Given this list of marker genes RAP1B, LNPEP, DDRGK1, CEP95, EBP, HASPIN, DOCK2, TRAM1, CIMIP4, SUOX, TTLL8, MKRN2, RASL11A, GAS7, MON1B, C2orf76, PPP2R5A, GAN, BNIP2, INAFM1, PEA15, ALKBH7, FAM241A, CMTM6, STMN1, SEPTIN2, RAD23A, IGBP1, TBCB, PCDHB16, GP1BA, CGAS, AKTIP, RIDA, KLHL42, FOXO3, RBM42, FGF11, AHDC1, LXN, CDC42SE1, CYTH2, CAMK2G, PPP3CC (NCBI Gene Id 5533), ARHGAP9, MLLT6, TRMT10B, MRPL33, ZNF394, HMGCR (3-hydroxy-3-methylglutaryl-CoA reductase), EDC4, LGALS1 (galectin 1), TACC3, TNS2, FZD5, RFTN1, WDR53, HEXB, CEP55, TRIM24, DNMT1, TTC39C, DPCD, CRIPT, PSKH1, ERCC6L, RAP2B, CAPN2, IDH3A, CAMK1D, CYB561A3, RASSF7, BTD, GATA3 (NCBI Gene Id 84828), NFATC3, TECPR1, ATAD1, CALB1, CIMIP5, SUPT4H1, BTG2, FKBP4, PPM1H, SNAI3, STARD7, LPIN1, THUMPD1, PIMREG, SGCB, ITGB7, SYNJ1, EMP3, ANXA4, RNF44, G2E3, ZFAND4, DNAJB1, CDKN2AIP, COMMD7, ACOT8, NCALD, CD96, PKMYT1, AUNIP, STK10, ACOT9, PPM1G, GP5, DNAJB4, ATP10A, SLC20A1 (solute carrier family 20 member 1), GPR87, C14orf93, SPRY2, MARK2, PAG1, GSS, ARL4A, PEDS1, GZMM, PEX5, CKLF, SEPHS2, HCLS1, ZNF335, LRRC8C, VCL, CD164L2, CUTA, REXO5, GNPTG, NIBAN1, SYNGR3, GBP2, OAS2, TREX1, KLC4, LAIR1, ABRACL, FAM204A, LGALS8, CASP7, ITPA, ETS1, HNF4G, GLIPR2, HSPG2, ADGRE5, CYP2D6, ARHGAP19, IKZF1, FCGR2B, TKTL2, NDC80, KIF23, RCN1, CLIC4, ULBP1, GSR, MEGF9, AIMP1, LRRC57 (leucine rich repeat containing 57), DIAPH3, GPSM2, NPC2, KCNAB2, PNLIPRP2, PLEKHF1, ARHGEF2, MYO1F, CYP2S1, AP1G2, ZNF414, USO1, NCCRP1, CERS5, TRAFD1, FAM177A1, GNA11, TUBGCP3, ATOX1, PXYLP1, SGK3, ATL2, PTBP3, MED27, MANF (mesencephalic astrocyte derived neurotrophic factor), ATG7, DHRS7, P2RY13, CDKN3, OSBPL3, MLYCD, STXBP5, EHD4, ANAPC5, KDM4A, APRT, DKK4, PDCD6IP, here is a description of the gene set: from publication Kress E, Hedges JF, Jutila MA (PMID 16423401) Human Gene Set: GSE3720_VD1_VS_VD2_GAMMADELTA_TCELL_WITH_LPS_STIM_DN The two major human gd T cell subsets, Vd1 and Vd2, display differences in tissue tropism and agonist responses, but we have little insight into global differences that may exist at the gene expression level. This is due to the small numbers of these cells that can be obtained from healthy donors, which limit comprehensive, comparative gene expression analyses. We established a culture method that expands Vd1 and Vd2 cells from the same PBL preparation to levels sufficient for sorting and microarray analysis. Although the subsets were expanded identically (anti-TCR mAb, plus IL-15), 392 and genes were identified, which were differentially expressed in the two subsets, from two donors, respectively. Approximately genes changed in both subsets following PMA/ionomycin treatment; about 50% of these genes were subset-specific. Both subsets responded to a crude LPS preparation, but only 6% of the responsive genes were the same. The differentially expressed genes were consistent with Vd2 cells being more inflammatory and Vd1 cells having more of a regulatory phenotype. Both subsets expressed transcripts encoding an array of innate and NK cell receptors, supporting the relationship of gd T cells to the innate immune system. Our results show that circulating Vd1 and Vd2 subsets in humans have considerable, inherent differences in gene expression following treatment with non-TCR agonists, supporting unique functional roles for these cells in vivo. Genes down-regulated in gamma delta T cells stimulated by LPS: Vd1 versus Vd2. studied in species Homo sapiens